The following is a description of a gene set: studied in species Mus musculus Glucose metabolism Mouse Gene Set: REACTOME_GLUCOSE_METABOLISM, and this is the list of marker genes: Pfkfb2, Nup35, Pcx, Gnpda1, Nup43, Nup133, Pfkfb4, Pkm, Eno4, Pfkm, Pgam1, Nup214, Nup93, Tpi1, Nup160, Eno3, Nup210, Gckr, Nup153, Gck, Nup37, Hkdc1, Slc37a1, Nup88, Fbp2, Pgm2l1, Fbp1, Nup42, Pgk2, Pom121, G6pc3, Hk3, Pfkfb3, Pck2, Slc37a4, Nup50, Nup58, Nup54, Nup205, Ndc1, Hk2, Nup85, Slc37a2 (solute carrier family 37 (glycerol-3-phosphate transporter), member 2), Gnpda2, Seh1l, Tpr, Aaas, Gapdh, Hk1, Rae1, Aldoc, G6pc1, Gpi1, G6pc2, Aldob, Sec13, Pgk1, Bpgm, Nup188, Ranbp2, Nup62, Pgam2, Pck1, Nup98, Eno2 (enolase 2, gamma neuronal), Pfkp, Pfkl (phosphofructokinase, liver, B-type), Adpgk, Gapdhs, Nup155, Aldoa, Pfkfb1, Nup107